Given this list of marker genes MICAL1, AGMO (alkylglycerol monooxygenase), HNRNPLL, CLEC9A, APOF, FBXO32, TMEM106B, CRAT, TRPV2, ESCO2, GRAP2, NR1I3, TOP2A, KIF9, SERINC5, CYRIA, TMEM59, LTF (lactotransferrin), MOB3A, COBLL1, SPIRE1, TTC32, PPP1R21, SDC3, TUG1, RUNX2, ABCA7, PRCP, SLC14A1, ZBTB1, ANKRD44, TMEM9B, FRMD4A, YPEL2, ADAM15, GDI1, SMO, RAPGEF4, HCFC2, GOLPH3L, PODXL, SORT1, HSD11B1, KLF2, TMEM63A, ACSL6, DCLK2, TSPO2, TMEM71, RBL1, RASGRP3, MMP8, CERS4, SMARCA2, HES1, SAMHD1, RGL2, STARD8, ANO6, FLACC1, IL1RL1, ETS1, PITPNC1, ST3GAL1, GBP5, RGS14, GNG2, LYN, SGO1, KLHL14, FERMT3, MAPRE3, SLPI, CYRIB, ADGRE5, ST6GAL1, SLC25A37, TMEM109, RHOH, TRIM34, CIITA, VRK3, KIF21B, TFEB, UBE2L6, SYPL1, RSU1, DMPK, LRP5 (LDL receptor related protein 5), STOM, CALHM2, PHACTR2, NFAM1, PRKD2, DPP4, AURKA, KCNJ10, ARHGEF18, PPP1R9B, FUT8, CDH17, MBOAT1, PXMP4, DCTN5, AQP1, CKLF, TMEM176A, ITSN2, MSR1, ZZEF1, MCTP2, ARHGAP9, PBX1, GTF2IRD1, KLHL5, CARMIL2, DNER, RIPOR2, KIF23, MBD5, HBEGF, EPSTI1, HEPACAM2, MTMR4, PGGHG, HEMGN, TRIM59, TREML2 (triggering receptor expressed on myeloid cells like 2), GSTP1, S100A6, GIMAP3P, GLO1, CAMK2D, CXCL11 (C-X-C motif chemokine ligand 11), DGKA, DGKI, BFSP2, FAM222A, SLC16A7, PDE1B, ABCD1, SNX20, FGL2, TET1, SGK3, SH3BP1, ZDHHC2, KYNU, ANPEP, CDK14, CD81, PRKAR2B, SELL, SOAT1, CD300C, MEFV, PI4KB, NXPE4, KCNA2, TLR6, LPAR5, BRWD1, PCP4, STARD9, AGAP1, PTPN4, TCP11L2, MAPK14, SKA1, here is a description of the gene set: Human Gene Set: GSE40274_CTRL_VS_FOXP3_AND_EOS_TRANSDUCED_ACTIVATED_CD4_TCELL_UP The transcription factor FoxP3 partakes dominantly in the specification and function of FoxP3+ CD4+ T regulatory cells (Tregs), but is neither strictly necessary nor sufficient to determine the characteristic Treg transcriptional signature. Computational network inference and experimental testing assessed the contribution of several other transcription factors (TFs). Enforced expression of Helios or Xbp1 elicited specific signatures, but Eos, Irf4, Satb1, Lef1 and Gata1 elicited exactly the same outcome, synergizing with FoxP3 to activate most of the Treg signature, including key TFs, and enhancing FoxP3 occupancy at its genomic targets. Conversely, the Treg signature was robust to inactivation of any single cofactor. A redundant genetic switch thus locks-in the Treg phenotype, a model which accounts for several aspects of Treg physiology, differentiation and stability. studied in species Homo sapiens from publication Fu W, Ergun A, Lu T, Hill JA, Haxhinasto S, Fassett MS, Gazit R, Adoro S, Glimcher L, Chan S, Kastner P, Rossi D, Collins JJ, Mathis D, Benoist C (PMID 22961053) Genes up-regulated in CD4 T conv: control versus over-expression of IKZF4 and FOXP3.